Given this list of marker genes ITPR3, ASTN2, SYT2 (NCBI Gene Id 6858), ADAP2, ADAP1, here is a description of the gene set: studied in species Homo sapiens Human Gene Set: GOMF_INOSITOL_1_3_4_5_TETRAKISPHOSPHATE_BINDING Binding to inositol 1,3,4,5 tetrakisphosphate.